The following is a description of a gene set: studied in species Mus musculus Binding to a protein kinase A. Mouse Gene Set: GOMF_PROTEIN_KINASE_A_BINDING, and this is the list of marker genes: Akap10, Sphkap, Pakap, Arfgef1, Akap7, Rara, Rab13, Akap8l, Csk, Akap3, Rdx, Lrba, Prkar2b (NCBI Gene Id 19088), Akap9, Dact3, Gskip, Wasf1, Gsk3b, Kcnq1, Spatc1l, Wasf2, Akap4, Akain1, Sox9, Myrip, Wmp, 1700019D03Rik, Akap8, Prkaca, Pkia, Arfgef2, Akap13, Ezr, Smo, Pja2, Acbd3, Akap1, Nbea, Prkar1a, Crybg3, Akap17b, Rps3 (ribosomal protein S3), Akap6, Wasf3, Prkar2a (NCBI Gene Id 66210), Akap14 (A kinase anchor protein 14), Prrc1, Dact1, Akap12, Gria1, Akap11, Prkar1b, Akap5, Lrrk2, Ryr2, Dact2, Gsk3a